Given this list of marker genes PPIP5K2, SLC6A1, SCN3B, TRIM55, AP1S3, PMM1, C6orf141, LINC01641, RORA, LINC00581, RNU6-916P, ENSG00000200235, OR5AQ1P, ITGAL-AS1, RPL36, KAT8, IL16, HEBP2, RNU6-166P, DUS2, MB, LYN, NFYC, LINC01235, CDC37, RNU1-141P, COQ10A, SRSF8CP, GTF2I, ARMH3, HSFY1P1, GXYLT2, PLA2G4C, TPRXL, MIR4510, MIR3162, RN7SL344P (NCBI Gene Id 106480503), STX4, LTK, LINC00929, PTPN2, C1orf87, CYP1B1-AS1, RPL3P1, CCDC40, SDC4, RPL32P27, RRN3P1, MORF4L1P5, RN7SKP270, VPS39 (VPS39 subunit of HOPS complex), CDCA7P1 (CDCA7 pseudogene 1), MIR764, CMKLR2-AS, LPGAT1, SPMIP10, RNU6ATAC36P, NLE1, RFC1, MTND3P4, PRAMEF29P, GC, TRPV1, LINC02390, C2CD5-AS1, TULP2, CDK4, NUCB1-AS1, UMOD, RNU4-62P, NAPSA, SHOC1, BORCS6, ACER3, SDAD1P3, MTND1P14 (MT-ND1 pseudogene 14), PRPF38AP1, RPS27P6, HAPLN2, ACKR2, ST7L, MTO1, CELF2-AS2, GLG1, MED21, H3P44, ENSG00000244137, LIPA, TRIM15, LINC01485 (NCBI Gene Id 101928154), FAM177A1P1, SLC22A11, UTP4, DAZAP2, LINC02576, CWC25, MIR3611, RN7SL93P, TMX1P2, SLFN12, TPM4P1, GIT2, FES, CASD1, TTC1, TNFRSF12A, TRAV15, COPS5P1, FRMD7, ZNF863P (NCBI Gene Id 100419682), QSER1, MIX23, ATP9B (NCBI Gene Id 374868), BBLNP1, GDPD5, H3P10, DDX46, ACACA, COPS3, SNHG30, HNRNPMP2, MAPK6P4, SPATS2L, SH2B3, PVT1, MIR3529, ENSG00000233242, TNFRSF10B, ADA, ENSG00000202059, DNAI4, CD160, AKAP9, LUZP1, IFT57P1, RPL21P20, ASS1P5, CLDN23, RNU6-1003P, OR1X1P, SNORD81, CCDC65, ANGPTL6, PPATP1, SYCE2, FMN2, RNU6-386P, MCTS1, EIF3F, SDHAF1, RLIG1P2, MIR3908, RB1CC1, COL25A1, NPAT, GALNTL5, RPL39P18, GAS8, ANGEL1, ALDOA, KRT18P45, CENPV, PLA2G15, PTK2B, RPL36P2, CARS1, GLRX5P2, AURKB, ESPN, SNAP25, IGSF21, LIM2-AS1, TRPM6, FOXP1-AS1, TGFB1, TTLL13, LYPLA2P1, FCHO2, OR1X5P, WNT8A, SSX7, TMEM98, GDI2, SMCR2, NOL6, ENSG00000243004, FABP5P3, RNU6-847P, CTNNA2, CFAP299, DAGLB, RNU6-1340P, TOP3B (DNA topoisomerase III beta), RND1, AGAP5, MTFMT, AGMAT, ENSG00000187951, RNU6-612P, CXXC1, MLST8, CNDP2, ILDR1, ITIH3, SOX9-AS1, YEATS2, EXOSC2, TNRC18, ARPC1A, PFAS, MAP4K5, TCEAL8P1, DHTKD1, ANKRD33BP7, RNA5SP474, ENSG00000265246, OR7A17, JAZF1-AS1, SLC25A16, SPEG, GABARAPL3, CROCCP3, ZNF675, VOPP1, CEACAM21, ZEB2P1, YAP1P1, JHY, PPP1R42, here is a description of the gene set: studied in species Homo sapiens Human Gene Set: ZNF697_TARGET_GENES from publication Yevshin I, Sharipov R, Kolmykov S, Kondrakhin Y, Kolpakov F (PMID 30445619) Genes containing one or more binding sites for (ZNF697) in their promoter regions (TSS -1000,+100 bp) as identified by GTRD version 20.06 ChIP-seq harmonization.